The following is a description of a gene set: Visual agnosia The condition is known as visual agnosia, which refers to the inability to recognize objects that are visually presented, even though the individual may have normal visual field, acuity, color vision, brightness discrimination, language, and memory. studied in species Homo sapiens Human Gene Set: HP_VISUAL_AGNOSIA, and this is the list of marker genes: TREM2, TMEM106B, ABCD1, PSEN1, CHMP2B, GRN, MAPT (microtubule associated protein tau), CEP85L